Given this list of marker genes Oprl1, Pde10a, Grk5, Gsk3a, Grk2, Pomc, Mrap2 (NCBI Gene Id 640967), Mgrn1, Crtc3, Pde4d, Ptger3, Sstr4, Arrdc3, Adrb1, Pde2a, Mrap, Aplp1, Rack1, Pde3a, Gnai2, Atp2b4, Oprm1, Pde4a, Nos1, here is a description of the gene set: Any process that modulates the frequency, rate or extent of an adenylate cyclase-activating G protein-coupled receptor signaling pathway. studied in species Mus musculus Mouse Gene Set: GOBP_REGULATION_OF_ADENYLATE_CYCLASE_ACTIVATING_G_PROTEIN_COUPLED_RECEPTOR_SIGNALING_PATHWAY